Given this list of marker genes MASP1, TBX1, MAP2K2, CITED2, FGFR3, PEX13, PEX26, FLT4, GATA4, LIG4, PEX16, BRAF, GHR, PIK3CD, PEX5, TRAPPC9, GATA6, HBA1, SIK3, SKIC3, GDF1, PEX2, PEX6, MYOD1, ESCO2, PEX10, NKX2-5, PEX19, NKX2-6, DRG1, GATA5, RBM10, SOX11, PTCH1, FGFR2, PRMT7, PEX3, JAG1, LZTR1, PPP1R21, MEGF8, KDR, MAP2K1, SLC25A24, PEX1, KRAS, TCF12, HBA2, PEX12, RAB23, PEX14, NSUN2, SPOP, NEU1, GJA5, TWIST1, ANTXR1, PEX11B, KNSTRN, KIF11, ZFPM2, ZIC1, here is a description of the gene set: Underdeveloped supraorbital ridges Flatness of the supraorbital portion of the frontal bones. Human Gene Set: HP_UNDERDEVELOPED_SUPRAORBITAL_RIDGES studied in species Homo sapiens